Given this list of marker genes FAM111A, SPATA22, CYB5A, CNBP, TAF4B, MCM9, TERT, NHLH2, WT1, POU1F1, ESR2, PRDM13, MCM8, MSH4, SMARCB1, PDGFB, GDF9, FGD1, HROB, GATA4, ZMYND15, TP63, NSMCE2, WWOX, PPP2R3C, ZFPM2, KISS1, GCNA, MAP3K1, CBX2, STAG3, KISS1R, FSHB, FKBP6, LHX4, DMXL2, SOHLH1, BNC1, FIGLA, LHX3, ARMC12, FANCM, SEMA3A, DHX37, ANOS1, SPIDR, CPE, SMARCE1, NR0B1, MSH5, PROP1, CLPP, AKT1, PSMC3IP, LGR4, FEZF1, PNPLA6, MANF, SMO, MRPS22, POR, XRCC2, SUFU, SLC30A7, ERCC6, BMPR1B, ZSWIM7 (zinc finger SWIM-type containing 7), VAMP7 (vesicle associated membrane protein 7), FOXL2, AR, PIK3CA, NR5A1, TAC3, MEIOB, SHOC1, OTX2, BAP1, LHB, KASH5, NF2, C14orf39, CYP11A1, HESX1, CYP17A1, HFM1, SOX9, SYCE1 (synaptonemal complex central element protein 1), SRY, TRAF7, SYCP2L, DIAPH2, ROBO1, here is a description of the gene set: species: Homo sapiens Human Gene Set: HP_ABNORMAL_CIRCULATING_FOLLICLE_STIMULATING_HORMONE_CONCENTRATION Abnormal circulating follicle-stimulating hormone concentration An anomaly of the circulating level of follicle-stimulating hormone (FSH).